The following is a description of a gene set: species: Homo sapiens Human Gene Set: GOMF_SYNDECAN_BINDING Binding to syndecan, an integral membrane proteoglycan (250-300 kDa) associated largely with epithelial cells., and this is the list of marker genes: HPSE, TNC, SEMA5A, SDCBP, GPNMB (glycoprotein nmb)